Given this list of marker genes Mre11a (MRE11A homolog A, double strand break repair nuclease), Ddx23, Srpk2, Rad50, Nfat5, Ddx21, Sirt7, Primpol, Nbn, here is a description of the gene set: A DNA metabolic process that results in the disassembly of R-loops. R-loops are three-stranded nucleic acid structures consisitng of an RNA:DNA heteroduplex and a looped-out non-template strand. Aberrant formation and persistence of R-loops block transcription elongation and cause DNA damage. Mechanisms that resolve R-loops are essential for genome stability. Mouse Gene Set: GOBP_R_LOOP_PROCESSING studied in species Mus musculus